The following is a description of a gene set: from publication Torchia EC, Boyd K, Rehg JE, Qu C, Baker SJ (PMID 17875932) Genes up-regulated in leukemic progenitor cells expressing activated fusion of ESWR1 and FLI1 compared to normal hematopoetic progenitors. studied in species Mus musculus EWS/FLI-1 is a chimeric oncogene generated by chromosomal translocation in Ewing tumors, a family of poorly differentiated pediatric tumors arising predominantly in bone but also in soft tissue. The fusion gene combines sequences encoding a strong transactivating domain from the EWS protein with the DNA binding domain of FLI-1, an ETS transcription factor. A related fusion, TLS/ERG, has been found in myeloid leukemia. To determine EWS/FLI-1 function in vivo, we engineered mice with Cre-inducible expression of EWS/FLI-1 from the ubiquitous Rosa26 locus. When crossed with Mx1-cre mice, Cre-mediated activation of EWS/FLI-1 resulted in the rapid development of myeloid/erythroid leukemia characterized by expansion of primitive mononuclear cells causing hepatomegaly, splenomegaly, severe anemia, and death. The disease could be transplanted serially into naïve recipients. Gene expression profiles of primary and transplanted animals were highly similar, suggesting that activation of EWS/FLI-1 was the primary event leading to disease in this model. The Cre-inducible EWS/FLI-1 mouse provides a novel model system to study the contribution of this oncogene to malignant disease in vivo. Mouse Gene Set: TORCHIA_TARGETS_OF_EWSR1_FLI1_FUSION_UP, and this is the list of marker genes: Rgl1, Cap2, Asb1 (NCBI Gene Id 98461), Arhgef2, Ltc4s, Mob1b, Cd5l, Pcx, 1110032F04Rik, Dusp10, Nt5c3, Gramd2b, Serpinb9, Schip1, Alox5, Lyrm9, Serpinb2, Car13, Cpt1c, Mr1, Meak7, Gnaq, Sowaha, Plxdc1, Cytip, Mest (NCBI Gene Id 30889), Tmem62, Lpar6, Pkp3, Fry (FRY microtubule binding protein), Cish, Hhex, Rspry1, Nfic, P2rx1, Klrg1, Cdkn2b, Sp100, Iffo1, Apoa1, Vsig10, Tnfrsf18, Mpped2, Dclk2, Arsa, Akt3, Zfp185, Fmo1, Pcdh7, Mavs, Faah (fatty acid amide hydrolase), Slc48a1, Cpne7, Prkch, Pgm2l1, Gpx2, Phlda2, Camk1d, Tecpr2, 4930550C14Rik, Ptprj, Slc6a20a, Acat1, Dock11, Il1rl1, Rnf227, Otub2, Runx1, Pcbp3, Stim2, St8sia4, Fgd6, Arel1, Pafah2, S1pr4, Ypel5, Shank3 (SH3 and multiple ankyrin repeat domains 3), Frmd4a, Pygl, Eps8, Ankrd9, Grb2, Slc35d2, Tmcc3, Ptger3, Rusc1, Neat1, Zfyve16, Trim47, Gna14, Vopp1, Cd59a, Rcbtb2, Ugt8a (UDP galactosyltransferase 8A), Gpr150, Rab27b, AI467606, Mxd4, Sphk1, Plek2, Apobec1, Nudt11, Pbx3, Fam174b, Cplx2, Optn, Slc45a3, Cpne5, Grk6 (G protein-coupled receptor kinase 6), Il18r1, Tjp1, Vcam1 (vascular cell adhesion molecule 1), Cttn, Cmah, Mars2 (NCBI Gene Id 212679), Nxf3, S100a13, Stx7, Gnb4, Gspt2, Gsdma, Tmem26, Bbx, Adcy9, Fermt3, Slc25a11, Rab11a, Emp3, Tnni3, Taf9b, Acadsb, Srxn1, Naglu, St6galnac3, Col5a1, Eeig1, Dcxr, Tmed8, Nfe2, Nrip3, Fnbp1l, C1qtnf4, Ibsp (integrin binding sialoprotein), Def6 (NCBI Gene Id 69722), Pgap6, Cdc42ep5, Tle3, Pitpnm1, Mvd, Grk5, Samd13, Ttc39b, Cda, Grtp1, Gpcpd1, Klhl6, Folr1, Pxmp4, Unc5cl, Sgk3, Orai2, Smim3, Homer3, Slamf1, Hmgcs2, Ndrg2, Plscr4, Aldh5a1, Grn, Apoe, Ttc23, Gda, Nol4l, Fdft1, Cdkn2c, 4930523C07Rik, Bcas3, Mapt, Tspoap1, Ppp1r13b, Tmem64 (NCBI Gene Id 277829), Zfp324, Ccdc186, Ankrd27, Acvr1b, Castor1, Kdm7a, Prkce, Lyst, Arap2, Macrod2, Trim26, Tbcel (NCBI Gene Id 78293), Tgfa, Gdf3, Xkr6, Tmem9b, Boll, 2810030D12Rik, Mtcl2, Arl4d, Rsu1, Dnaja4, Tsc22d2, Pon3, Dip2c, Id2, Cmas, Eeig2, Tent5a, Car8, Atxn7l1, Popdc2, Bbc3, Pecam1, 5033406O09Rik, Rfk, Kdm5b, Klf6 (Kruppel-like transcription factor 6), Rbl2, Ncoa3, Nbea, Ero1b, Cacna1c, Mtmr12, Pdlim5, Bex4, Prkcq, Tg, F2r, Hey2, Zdhhc9, Ypel2, Gp5, Homer1, Fcna, Atp2a3 (NCBI Gene Id 53313), Pcyt1b, Platr30, Clca3a1, Niban2, Serpinb6b, Dennd2c, Crem, Prxl2a (peroxiredoxin like 2A), Diaph1, Mob3c, Bmt2, Nmnat2, Zmiz1, Ldhc, Derl1, Golph3 (NCBI Gene Id 93791), Eldr, Slc43a1, Fuom, Tsc22d3, Arl2bp, Itgb7, Enpp5, Trim10, Hsd3b7, Sergef, Icam2, Tmprss6 (transmembrane serine protease 6), Tspan32, Zmat3, Wdr7, Ppm1e, Tmem184a, Pgap4, Mst1, Ddit4, Mgat5 (mannoside acetylglucosaminyltransferase 5), Tom1l1